Given this list of marker genes Nek11, Wdr76, Brd4, Fancd2, Donson (NCBI Gene Id 68649), Cdt1, Ier3, Nop53, Sde2, Ufl1, Gigyf2, Cdk2ap2, Rpl24, Brcc3, Atr, Brd7, Bard1, Zfy2, Gpr132, Trex1, Abraxas1, E2f1, Setmar, Cul4a, Cdc5l, Acvr1, Nek2, Mbtps2, Haspin, Cdc5lrt9, Plk3, Chek1, Stk38, Tpra1, Rad50, Lcmt1, Brca2, Fbxo5 (NCBI Gene Id 97658), Atf2, Dcun1d3, Susd2 (NCBI Gene Id 71733), Ptprv, Rps6, Miip, Rps27l, Fbxo7, Rb1, Creb3l1, Grb14, Zfp830, Ctdsp1, Mus81, Gas1, Hus1, Stk33, Rgcc, Ovol1, Dact1 (NCBI Gene Id 66738), Fbxo31, H2ax, Klf4, Pkmyt1, Mre11a, Stk35, Gnb1l, Ik, Fbxo4, Cacnb4, Recql4, Fhl1, Cdc5lrt5, Fem1b, Dlg1, Ccnb1-ps, Kat2a, Cdc73, Atm, Btn2a2, Babam2, Fzr1, Ccnb1, Usp28, Cenpe (centromere protein E), Mos, Tpr, Msh2, Pten, Sox2, Zfp36l2, Wee1, Plk1, Bcl2, Wac, Zwilch, E2f8, Klhl22, H2-M3, Nabp2, Zfp36l1, Fgfr3, Psmg2, Nanos2, Prap1, Pabir1, Gper1, Dtl, Rad9b, Clspn, Rps6ka2, Trp53, Apc, Prox1, Hsf1, Foxn3, Apbb1, Brca1, Rbl1, Rad21, Dync1li1, Inhba, Tiprl, Ticrr, Cry1, Rad51, Wapl, Zfyve19, Bmp4, Vps4a, Cdkn2b, Nubp1, Tipin, Chfr, Esr1, Bub3, Syf2, Timeless, Cdc20, Mbd4, Fam107a, Ccnd1, Anapc15-ps (anaphase promoting complex C subunit 15, pseudogene), Nme6, Eif2ak4, Trim37, Rbbp8, Atf5, Rad17, Nae1, Cdc14b, Babam1, Kntc1, Xrcc3, Ezh2, Mir26b, Gpr15lg, Nbn, Gpnmb, Prpf4b, Smarca5, Crlf3 (cytokine receptor-like factor 3), Khdc3, Cdc6, Ppp2r3d, Rpa2, Zwint, Gjc2, Diaph3, Hus1b, Rhno1, D7Ertd443e, Taok3, Myo16, Ppp1r10, Chmp2a, Mad2l1, Dmrt1, Rad9a, Spc24 (SPC24, NDC80 kinetochore complex component, homolog (S. cerevisiae)), Zc3h12d, Usp47, Kat2b, Cdc5lrt4, Kifc1, Ctdspl, Baz1b, Fgfr2, Pdik1l, Pkd2, Cdc5lrt6, Birc5, Npm1, Ints7, Ccnf, Mettl13, Cdk5rap3, Aven, Nek1, Chek2 (checkpoint kinase 2), Brcc3dc, Hormad1 (NCBI Gene Id 67981), Cep63, Ccl12, Cenatac, Aurkb, Ctdsp2, Usp44, Blm (Bloom syndrome, RecQ like helicase), Parp9, Stil, Map3k20, Apbb2, Chmp4c, Brsk1, Tex14, Cdkn2d (cyclin dependent kinase inhibitor 2D), Bub1b, Dtx3l, Jade1, Anapc15, Mdc1, Incenp, Spdl1, Hinfp, Mir26a-2, Cdca8, Prkdc, Topbp1 (NCBI Gene Id 72768), Cdk5rap2, Slfn1, Eme2, Rbm14, Mdm1, Nuf2, Rbl2, Bmp7, Mbtps1, Fbxo43, Dna2, Nsun2, Ttk, Ndc80, Ptpn11, Zfp655, Ints3, Trip13, Tom1l2, Orc1, Etaa1, Bub1, Rint1, Mrnip, Zfp207 (zinc finger protein 207), Cdc5lrt1, Mir26a-1, Knl1, Foxo4, Tnks, Taok2, Gen1, Trrap, Macroh2a1, Atrx, Inip, Tom1l1, Znhit1, Rfwd3, Apbb3, Pinx1, Osm, Mad1l1, Ccng1 (NCBI Gene Id 12450), Cdc5lrt7, Tmsb4x, Nabp1, Sirt1, Ska1, Rad1, Dot1l, Prmt2 (NCBI Gene Id 50502, protein arginine N-methyltransferase 2), Mapk14, Cdc5lrt8, Aurka, Atrip, Trp53bp1, Lif, Xpc (xeroderma pigmentosum, complementation group C), Mad2l1bp, E2f7 (E2F transcription factor 7), Tti1, Men1, Cdkn1a (NCBI Gene Id 12575), Cdc5lrt10, Lyn, Naa10, Ppp2r5b, Cdk1, Ccar2, Clock, Pcid2, Rnaseh2b, Eme1, Arhgap33os, Dab2ip, Taok1, Chtf18, Zw10, Tmem67, Dgkz, Mtbp, Uimc1, Kank2, Ska3, Dusp1, Poc5, Ercc6, Prpf19, Trim39, Spc25, Cep192, here is a description of the gene set: Mouse Gene Set: GOBP_NEGATIVE_REGULATION_OF_CELL_CYCLE_PROCESS species: Mus musculus Any process that decreases the rate, frequency or extent of a cellular process that is involved in the progression of biochemical and morphological phases and events that occur in a cell during successive cell replication or nuclear replication events.